The following is a description of a gene set: species: Homo sapiens Human Gene Set: GOBP_MEMBRANE_LIPID_METABOLIC_PROCESS The chemical reactions and pathways involving membrane lipids, any lipid found in or associated with a biological membrane., and this is the list of marker genes: PIGB, FADS3, B4GALT4, FUCA1, SPTLC3, DEGS1, PGAP2, B3GALT4, SAMD8, GPAA1, PIGQ, PIGX, PIGT, CERS3, ACER2, ST6GALNAC3, GBA1, GBA2, SGMS2, SMPDL3B, B3GALT1, PRKD1, CLN8, ALOX12B, B4GALT6, FUT9, ST8SIA6, NAAA, SIRT3 (sirtuin 3), ABCA2, SCARB2, SMPD2, PIGH, HACD2, TM9SF2, SGPL1, FUT7, ST3GAL4, SMPD1, ST8SIA1 (NCBI Gene Id 6489), CREM, PPT1, PRKCD, GLB1, PIGM (NCBI Gene Id 93183), PEMT, PIGA, ST6GALNAC4, ENPP7, B3GNT5, NEU3, MGST2, ASAH2B, SLC30A5, FUT2 (NCBI Gene Id 93237), ALDH3B1, GALC, PIGL, PIGU, ELOVL3, A4GALT, ABCG2, NEU2, ST8SIA5, ELOVL5 (ELOVL fatty acid elongase 5), ELOVL4, DPM1, ST3GAL5, ZPBP2, HTRA2, PLA2G15, FUT5, NEU1, PLPP2, ST3GAL2, ST6GALNAC5, B4GALT5, CYP4F22, PGAP1, CYP1B1, PNLIPRP2, AGK, ST3GAL1, PLPP1, SUMF1 (NCBI Gene Id 285362), NAGLU, PIGW, PIGS, SGPP1, HACD3 (3-hydroxyacyl-CoA dehydratase 3), A3GALT2, PIGO, SPHK2, ABCC1, CERT1, GAL3ST2, B4GALT3, B3GALNT1, PIGZ, SPTSSB, C20orf173, ZNF750, PNPLA1, PIGN, PGAP4, PRKD2, CERS5, GAL3ST3, M6PR, MIR16-1, SERINC1, ST3GAL3, CERKL, CLN6, CERS4, PRKAA1, DPM2, ALDH3B2, MIR127, CSNK1G2, PIGK, PIGC, GAL3ST1, KDSR, CWH43, ETNPPL, ELOVL7, FUT6, MECR, PIGF, B3GALT2, SFTPB, HEXA, SMPDL3A, LARGE1, SPNS2, PIGY, TLCD3B, TNF, FUT3, ST8SIA3, PSAPL1, CERK, ASAH2, MFSD8, FUT4, HACD4, CERS1, PLPP3, VPS54, GBA3 (NCBI Gene Id 57733), BAX, P2RX1, ST8SIA2, TNFRSF1A, ACER1, GAL3ST4, LCT, MIR195, NEU4, PIGP (NCBI Gene Id 53821), NSMAF (NCBI Gene Id 8439), HEXB, PAQR4, ORMDL2, PRKD3, SPHK1, CERS2, GLA, SCCPDH, DEGS2, ENPP2, VAPA, UGT8, ST8SIA4, ASAH1, AGMO, PLA2G6, CCN1, MPPE1, ORMDL1, KIT, PGAP3, ORMDL3, ELOVL1, PIGV, ALOXE3, PIGG, GBGT1, UGCG, CEL, B4GALNT1, MFSD2B, CERS6, SMPD4, FUT1 (NCBI Gene Id 2523), TECR, ELOVL2, GM2A, SGMS1, SPTLC2, P2RX7, SPTSSA, NAGA, ITGB8, OSBP, FA2H, PPM1L, SGPP2 (sphingosine-1-phosphate phosphatase 2), ST3GAL6, ABCA12, ST6GALNAC6, DPM3, ELOVL6, ARV1, PSAP, SPTLC1, HACD1, TEX2, SMPD3, ACER3, ABCA8